Given this list of marker genes ATP13A2, FA2H, RARS1, MICU1, WDR73, ZNF592, GAMT, CLPB, PLA2G6, here is a description of the gene set: species: Homo sapiens Human Gene Set: HP_PROGRESSIVE_EXTRAPYRAMIDAL_MOVEMENT_DISORDER Progressive extrapyramidal movement disorder